Given this list of marker genes TBR1, FOXJ3 (forkhead box J3), IDE, ANKHD1, LINC01517, ODF2L, MTBP, EVI2A, AFF2 (NCBI Gene Id 2334), CDK6, C5orf63, FLRT1, DNAJB4, ST8SIA3, EFNA5, BNIP3 (NCBI Gene Id 664), CCDC73, CETN1, PABPC5, TCF7L2, SLC4A4, PTBP3, DMRTA1, SYNCRIP, HOXC8, DMRT3, SEL1L3, ZFAND6, FAM177A1, CYREN, PPARGC1B, ADGRF5, ATP2B3, LILRA1, RSBN1L, AHCYL2, RTL3, LRRC15, DPYSL2, MAP7D3, GCSH, OGT, VKORC1L1, DCHS2, CACNA2D1, NOTCH2NLA, POTEA, PLB1, CCDC62, MTPN, CALCOCO2, LRRC19, USP6NL, ZFP82, CTNND2, GJB2, ENPP5, ZNF782, CASK, AKIRIN1, TSC1, KRT27, ZNF568, PPP1R21 (protein phosphatase 1 regulatory subunit 21), ASB8, GLUD1, ZNF630, ACSBG1, EIF5A2, TMEM245, KCND2, MAOB, GLUD2, SMARCE1, ZNF268, RBM44, SLC35F1, RIMKLB, S1PR1, EML6, here is a description of the gene set: from publication Chen Y, Wang X (PMID 31504780) species: Homo sapiens Human Gene Set: MIR26A_2_3P Genes predicted to be targets of miRBase v22 microRNA hsa-miR-26a-2-3p in miRDB v6.0 with MirTarget v4 prediction scores > 80 (high confidence targets).